The following is a description of a gene set: Human Gene Set: GOMF_RRNA_URIDINE_METHYLTRANSFERASE_ACTIVITY species: Homo sapiens Catalysis of the reaction: S-adenosyl-L-methionine + rRNA = S-adenosyl-L-homocysteine + rRNA containing methyluridine., and this is the list of marker genes: MRM2, FDXACB1, FTSJ3, SPOUT1, TRMT2B